Given this list of marker genes Gsta2, Chac1, Ggt7, Gstm6, Mgst2, Gstm1, Ggt5, Gstt1, Gsta1, Ggt1, Gstp1, Chac2, Gsta13, Gstm5, Ggt6, Gstm2, Gstt2, Gstz1, Hpgds, Oplah (NCBI Gene Id 75475), Gsta3, here is a description of the gene set: electronically inferred by orthology from the curated human pathway part of: Phase II - Conjugation of compounds This event has been computationally inferred from an event that has been demonstrated in another species.<p>The inference is based on the homology mapping from PANTHER. Briefly, reactions for which all involved PhysicalEntities (in input, output and catalyst) have a mapped orthologue/paralogue (for complexes at least 75% of components must have a mapping) are inferred to the other species. Reactome Pathway: Glutathione conjugation studied in species Mus musculus